The following is a description of a gene set: An ionotropic glutamate receptor activity that exhibits fast gating by glutamate, acts by opening a cation channel permeable to sodium and potassium, and for which kainate is an agonist. Human Gene Set: GOMF_KAINATE_SELECTIVE_GLUTAMATE_RECEPTOR_ACTIVITY species: Homo sapiens, and this is the list of marker genes: GRIK3, GRIK1, GRIK2, GRIK4, GRIK5